Given this list of marker genes LPCAT3, MBOAT2, MBOAT1, PLA2G4E, PLA2G6, PLAAT2, PNPLA8, PLA2G2D, PLA2G4C, PLA2G3, PLAAT3, ABHD4, PLA2G1B, PLAAT1, PLBD1, PLA2G4B, PLA2G5, PLAAT4, PLA2R1, PLA2G4F (NCBI Gene Id 255189), PLA2G2A, PLA2G2F, PLA2G12A, PLA2G4D, PLA2G2E, LPCAT4, PLAAT5, PLA2G10, PLA2G4A, here is a description of the gene set: Human Gene Set: REACTOME_ACYL_CHAIN_REMODELLING_OF_PE Acyl chain remodelling of PE studied in species Homo sapiens